The following is a description of a gene set: Genes containing one or more binding sites for (OVOL3) in their promoter regions (TSS -1000,+100 bp) as identified by GTRD version 20.06 ChIP-seq harmonization. Human Gene Set: OVOL3_TARGET_GENES from publication Yevshin I, Sharipov R, Kolmykov S, Kondrakhin Y, Kolpakov F (PMID 30445619) species: Homo sapiens, and this is the list of marker genes: KIAA1586, PAPOLG, NELFE, PRPF31, SNRPC, KCTD7, SEC62, CSNK1G2, MIR4727, AKIRIN2, SMG8, COLGALT2, ZKSCAN8, IFTAP, JPX (JPX transcript, XIST activator), ZNF565, REXO4, H2AZ1 (NCBI Gene Id 3015), FANCC (FA complementation group C), NFIB, POC1A, ENSG00000187186, CDCA2, NTMT1, PSMD8, ATAD2, ZNF335, GBA1, OR2I1P, ITGA7, VPS33A, CCT6B, SSU72, RNU12, H4C3, RPL23AP53, FAT3, PLAU, H2AZ1-DT, BLOC1S1, ZC3H6, ZFP30, SDAD1, DHFR2, VDAC1, EIF2D, RPL37, FERRY3, ELF1, MTIF2, SCYL3, APEX1, CDK5RAP1, KDM5C, KPTN, INTS14, CDC27, NAPA-AS1, TFCP2, C1orf50, SEC22B, KTN1, ARFGAP3, EMSY, ATP6V0D1-DT, TM7SF3, MTUS1, HTRA2, FGD6, TTC32, RCBTB2, BASP1-AS1, DYNC2I2, PEF1-AS1, LAMP1, ID1 (inhibitor of DNA binding 1), TSPAN19, CCBE1, SMARCD2, NEURL2, ZNF576, MTFR2P2, SLC25A53, CENPF, LMF2, ERAP1, CLN3, TACO1, C12orf76 (chromosome 12 open reading frame 76), FAM133B, RFTN1, DRG2, AURKAIP1, GALNTL5, ANXA6, RUNX1, MKKS, SRGAP2, TMEM263-DT, VIM, MRPS34, BAX, CDC42SE1, NMNAT1, DALRD3, CTSA, ASH1L, SUOX, GLI3, COMMD4 (NCBI Gene Id 54939), RFC4, GTF2IP12, RDUR, MPHOSPH9, MAZ, ZNF420, FBXO15, SRCAP, FXR1, FHL1P1, ENC1, BUD13, ZNF529, C17orf58, ALKBH3, CREB3L2-AS1, FLI1 (NCBI Gene Id 2313), HOXA3, ZNF596, FAM72B, TTBK2, GOLGA3, PPAT, SLC35E2A, VPS51, GABARAP, LZIC, ING1, SNHG30, RBBP7, PHF7, ZSCAN31, REV1 (REV1 DNA directed polymerase), TAFAZZIN, MGARP, CRY1, NDUFC2-KCTD14, NAV2, FAM227B (family with sequence similarity 227 member B), TOP3B, CARS2, NSUN3, RMND1, TTC32-DT, PCBP2, POT1, IMPA1, STK16, MARCHF6, RPS26, ZEB1-AS1, TTC1, KCTD9 (NCBI Gene Id 54793), LRP6, SEPTIN7P14, GABPB2, INTS13, ANKLE2, METTL15 (NCBI Gene Id 196074), EXOSC2, MED11, SRRM2-AS1, PRDM6, NOSIP, CACYBP, RN7SL446P, SLC25A6, MIR5188, PAXIP1, PPHLN1, RPL11, MRPL39, ZCRB1, BASP1, ARMT1, PEF1, ZEB2-AS1, HOXB3, BUD13-DT (NCBI Gene Id 122455333), ZBTB5, PPP2R3B, ISLR2, ZSCAN16-AS1, RAD51AP1, PRDM6-AS1, PDCD6P1, RGS5, ASCC1, CFAP20, UBE2Q1, PTGES3, STARD10, CDC42EP4, ENSG00000277020, CALM2, RND1, PRKG1, TM9SF4, GTF2H1, ZNF276, NCAM1, CPVL, GPANK1, ZNF684, TCF3, ZSCAN30, ALDH9A1, RPL29, GIHCG, TUBGCP5, NME5 (NME/NM23 family member 5), SRGAP2C, ZFP82, ITGB3BP, CWF19L1, NRP1, MXD4, TMEM101, KIAA0319L, DPP9, ATP6V0D1, MIR7-3HG, GNB2, AP1M1, TP53BP2, TRAF6, AP2A1, KDSR-DT, ENY2, VPS13B-DT, ATE1OSP, DCAF7, DPP8, USP31 (ubiquitin specific peptidase 31), MFSD4B, COASY, DTWD1, EPHA4, ZNF76, C6orf226, TMEM248, VPS50, MRPS14, TTC5, RNVU1-15, ARID1A, KIAA0586 (KIAA0586), KLHL9, LIMA1, LINC01132, HOXB-AS3, UBOX5, NDUFS3, PDE8A, RPL36AL, CWC25, CEP85, UBE2S, HCG27, CDKN2AIPNL, MRPS2, OSGIN2, RNVU1-14 (NCBI Gene Id 101954266), MTRFR, AAAS, STT3B, SRSF1, PARN, BCAS2, EMSY-DT, CCDC163, RRM2B, UBE2L3, FAM21EP, PRRC2A, TMEM94, CNPY3, ENSG00000247416, SRRM2, PDE4DIP, HOXC4, RPL32P3, NAGPA, KLRK1-AS1, C1orf174, MRPL13, SLC39A3, MAP3K7, NDUFB1, SMG5, PHKA2, NDUFS7, ZKSCAN5, KAT5, HMGA2, POT1-AS1, RNU6-1039P, NUP155, CTPS1, BAP1, G6PC3, PAXBP1, ZMPSTE24-DT (NCBI Gene Id 120017338), GNG12-AS1, TPI1P2, ZEB1, PHF1, NFIA-AS1, RCOR3, PTPN2, MFSD4B-DT, LINC02960, HDGFL2 (NCBI Gene Id 84717), ARAP1, C5orf15, KDSR, GCHFR, NPAS1, ZDHHC17, GLB1L, P3H1, GALNT16-AS1 (GALNT16 and EXD2 antisense RNA 1), IFT88, MIR7-3, WBP4, CCDC144BP, UBC, DNAJB6, DVL2, GARIN5A, ALG1, NUDCD1, ZNF3, ZNF599, TAGLN2, MIR5695, DLC1, ZNF688, MTF2, FGFR1OP2, MGAT2, SLC31A1, ZFPL1, DNAJB1, CDCA5, ABCD3, TIMM21, FAM72A, RIC8B, EXOSC3, KIAA0319, ZMPSTE24, TMEM79, FKBP15, EMC10, INTS12, UBR5-DT, HPS5, TARS2, DCAF13, SLC25A32, ZNF271P, CPSF2, NOP16, SRRM5, SPNS1, SMAD4 (NCBI Gene Id 4089), LTBP4, SEPTIN2, TRDMT1 (NCBI Gene Id 1787), SIX5, C12orf43, TENT5C, LEISA1, POLR3C (NCBI Gene Id 10623), IRGQ, NCDN, TMEM263, YWHAZ, ZKSCAN2-DT, SSU72-AS1, TBPL1, TMEM260, OSGEP, LINC01091, FASTKD5, AP1G1, DNTTIP1, CCDC88A, ZNF689, TXLNA (taxilin alpha), POLDIP3, NCAPH2, SRRT, LPCAT3, WDR45, NDUFA11, ATP13A1, ENSG00000232995, ATE1, RBM33-DT, CNRIP1, NR2F1-AS1, ABCF1, PDZD8, CEP120, FCHSD2, NDUFAF3, PIERCE1, ITFG2-AS1, NUF2, LINC01275, BRWD1, MSLNL, HDLBP, TSC22D4, MARCHF7, ADSL, CDK5RAP2, NR2F1, SYCE2, STK35, CSNK1D, MED21, CBX4, ZKSCAN2, MIR194-1, AUP1, SLC41A2, NDUFC2, VPS9D1, PAICS, GARNL3, ICE1, DNAJB12, KCTD5, SLC9A1, EFHC1, EPCIP-AS1, TAF15, VMAC, GSTCD, WASHC2A, PPP2R5C, KRT13, VEZT, NUB1, RPS7, LINC01775, ZBTB20, MAPK4, SLC24A1, BRPF1, ACBD6, MBTPS2, SLC25A28, NOL6, CSNK2B, CREM, LRRIQ1, THAP1, TARBP2, MTBP, MARCHF6-DT, SMAD1 (NCBI Gene Id 4086), HOXA9, LINC01003, GLIS1, TIMM9, RBM33, WFDC3, SKIC2, KBTBD4, SLX4IP, BRF2, FNDC3A, ZNF382, ZNF555, VLDLR-AS1, VAMP1 (NCBI Gene Id 6843), TFPT, SNTA1, TNPO3, MIR615, MTERF4, NOLC1, ENSG00000257346, RANBP3L, RPL39P40, SLC15A1, EXD2, PRR14, VPS13B, ZNF175, PSMC3, HOXA-AS3, DCP1A, ZEB2, DSTYK, EME2, PPP6R3, HEATR3-AS1, RAG1, MMACHC, EFCAB7